Given this list of marker genes Mrps34, Hsdl2, Rtkn (NCBI Gene Id 20166), Xrcc1, Lcmt1, Rmnd5b, Slc31a1, Rab10, Ssbp1, Mgst1, Rsrc1, Mrps18a, Ppp1r3f, Mfap3l, Lonrf3, Hsf1, 9230112J17Rik, Dock7, Tubg1 (NCBI Gene Id 76340), 1700021N21Rik, Spop, Xpo4, Col4a2 (NCBI Gene Id 12827), Dsn1, Ciao1, Ppbp, Eldr, Kdelr3, Ipp, Ccndbp1, Atg9b, Sdhaf3, Or2d3, Cfap410, Strada, Osbpl3, Vav2, Ifi35 (NCBI Gene Id 70110), Nedd4, 0610043K17Rik, Idi1, Gap43, Tmem126b, Hoatz, Osbpl9, Tcf4, Srprb, Mfap5, Col1a2, Rftn1, Ghr, Hdgfl2, Qng1, Ccdc181, Nudt14, Csrp1, Tnfrsf10b, 4930486L24Rik, Uchl3, Itpr2, Fam83d, Atl3, Tctn3, Dtd2, Gapdh, Slc48a1, 4930544F09Rik, Smoc2, Mllt10, Adsl, Cdc14b, Sdcbp2, Cpa4, Slc25a16, Gjb4, Tff1, Tram1, Fig4, Eif2s3x-ps1, Serpinb9, Tbc1d1, Plac8, Camkmt, Shisa9, Phf10, Chrne, Cfap298, Ntsr1, Atxn7, Insl6 (insulin-like 6), Ccdc47, Col11a2, Tmem126a, Qrsl1, Acta2, Pde6d, Grb10, Sprr1b, Vps26c, Mlkl, Ppil2, Hpcal1, Tnfrsf23, Rogdi, Prr5l, Rbms3, Tmem176a (NCBI Gene Id 66058), Snx1, Tlr4, Calm2, Eps8l2, Tspan5, Pla2g2d, Wdr5, Snrpd1, Cdk5rap1, Tarbp2, Ltb4r2, Psma1, Gde1, Cenpk, Dkk3, Gjb5, Acsl4, Chpt1, G6pdx, 6330403L08Rik, Ofd1, Rpain, Zbtb9, Ccne1, Pxdn, Alox5, Chmp4c, Exoc3l4, P3h3, Hmg20a (NCBI Gene Id 75713), Etnk1, Pex3, Rp9, Celsr3, Ttc39c, Unc5cl, Mnat1, Ccdc88c, Farp1 (FERM, ARH/RhoGEF and pleckstrin domain protein 1), Stx8, Spdye4a (NCBI Gene Id 74673), Gcsh, Tank, Cep131, Hs3st1, Tpmt, Nkiras1, Meg3, Kctd20, Ube2t, Atf5, Ptprk, Rsph9, Plin3, Slco3a1, 2610316D01Rik, Kank3, Steap3, Elk3, Ptgr1, Mbnl2, Rest, Nptx1, Slc46a1, Pycr1, Hspa14, Wwtr1, Myh6, Mtm1, Pde4b, Odf2l, Ttc7, Tmem41b, Atic, Rtraf, Cog1, Mcm2, Jak2, 1810055G02Rik, Meikin, Anxa1, Plek2 (pleckstrin 2), Ikbke, Efemp2, Lpar6, Acp6, Chaf1b, Ptp4a2, Phf6, Plet1, Ugt2a1, Pin4, Bloc1s2, Rad51, Pttg1, 2700097O09Rik, Npc1, Acot9, Pten, Cd2bp2, Ubac2, Snap29, Ntng2, Srrd, Cdpf1, Trmt10b, Tmigd1, Rcan3, Dohh, Fabp1, A930015P04Rik, Nudt21, Trim21, Cmtm3, Loxl2, Efcab15, Tsg101 (NCBI Gene Id 22088), Fbf1, Loxl1, Psmg1, Dck, Mipep (mitochondrial intermediate peptidase), Hmces (5-hydroxymethylcytosine (hmC) binding, ES cell specific), Diaph2, Tk2 (thymidine kinase 2, mitochondrial), Atp2b1, Tex2, Ldlr, Aamdc, Myom1, Echdc1, Klf13, Col4a5, Crtap, Usp17la, Nqo2, Pstpip1, Plin4, Gnb1l, Preb, Tnip1, Polr2j, Anxa6, Pccb, Spatc1, Crem, Col11a1, Nnmt, Ggct, Rexo5, Selp, Psmd10, Ubqln1, Pdxk, Ptpn11, Cdk9, Svep1, Pcdh12, Kifap3, Klf10, Lrrc8d, Matn2, Bmper, Zbed3, Vac14, Rin1, Gatm (glycine amidinotransferase (L-arginine:glycine amidinotransferase)), Dnajc7, Arhgap17, Atp6v1h, 1700088E04Rik, Abcb1a, Sap30l, 2310033P09Rik, Col6a3, Tfcp2l1, Xrn2, Scnm1, Zfp26, Psg23, Smim8, Hnrnpdl, Prim1, Ube3a, Tpd52l1, 1700010I14Rik, Tbcd, Fer, Sugt1 (NCBI Gene Id 67955), Tgfbr2, Timm21, Mus81, Dmrtc1c1, Wtap, Accs, Htra2, Tfpi2, Ms4a10, Mrpl49, Cdc45, Fam83g, Plpp1, Csnk2a1, Kif3a (kinesin family member 3A), Mplkip, Robo3, Nfu1, Shq1, Pdia5, Tmem238, Taok3, Ruvbl1, Cast, Smurf1, Prkar1a, Hyal2, Washc3, Aox3, Pwwp3a, Ptprg, Trappc2b, Ndufs3, Swap70, Taldo1, Bcas3, Plscr1 (NCBI Gene Id 54533), Pdrg1, Mark3, ENSMUSG00000125400, Cyp27a1, Rpap3, Pcgf5, 2310030G06Rik, Tpm2 (NCBI Gene Id 22004), Eral1, Prnp, Abcg8, Angpt2, Rp2, Fabp5, Clip1, Rcn1, Czib, Plscr2, Trappc6b, Ndufaf3, Adat2, Ankrd1, Ier3ip1, Nt5dc2 (NCBI Gene Id 70021), Nab1, Col1a1, Nmi (N-myc (and STAT) interactor), Cmc1, Capn1, Dnaaf8, Mrps22, Ormdl1, Klhl13, Rpa1, Dkk2, Uchl5, Hemk1, Agmat, Gsto2, Wdr54, Nid1, Riok3, Psat1, 4930438A08Rik, Ccdc103, Hmga2, Cops4, Fkbp7, Csnk1g3, Diablo, Tex9, 1700030I03Rik, 1810009A15Rik, Ptpn21, Cxadr, Snx27, Mrps28, Ttc17, Emc2, Uba2, Nans, Gemin2, Cst6, Tsc2, Hic1 (NCBI Gene Id 15248), Cdk1, Aifm1, Mlycd, Pex7, Ppat, Tbp, Dhrs7b, Dnttip1, Myl12a (NCBI Gene Id 98073), Ndufa1, Crnde, Ltbp4 (latent transforming growth factor beta binding protein 4), Samd8, Use1, Rn7s1, Pkd1 (polycystin 1, transient receptor potential channel interacting), Rgs17, Ccdc13, Gng11, Cibar1, Rln1, Nadk2, Pole2, Ccdc90b, Rbx1, Exosc3 (NCBI Gene Id 66362), Gatad2a, Ahcyl1, Ctu1, Wars2, Zcrb1, Actb, Pls3, Mib1, Suds3, Myo5c, Prss23, Wwox, Psph, E2f1, Paip1, Cenpv, Nup93, Psmd4, Sil1, Rbpj, Tjp2, Pitx1, Sfrp1, 4930407I19Rik, 1700003F12Rik, Setd6, Glyat, Abcg1, Nsmf, Cxcl14 (C-X-C motif chemokine ligand 14), Tipin, Stat6, Nid2, Tnc, Map4, Gabrb1, Eid3, Elovl7, Fam114a2, P4ha1, Cd40, Gpatch2, Agk, Myl6, Tpr, Bcl2l15, Eno3, ENSMUSG00000125971, Stk11, Snx5, Uck2, Tusc3, Rsu1, 5730480H06Rik, Dubr, Fto, A930019D19Rik, Colec12, Msh5, Prelid3b, Dcaf7, Mtap, Tardbp, 2810004N23Rik, Specc1l, Galnt2, Thbs2, Sh3d21, Gclm, Elmo2, Fkbp1a, Prl3d1, Hras, H2ax, Bcs1l, Arhgef1, Pigq, Immp2l, Gjb3, Meaf6, St3gal6, Grem1, Ppp6r3, Clns1a, Nit1, Piwil1, Ubap2, Mettl5, Ccdc34, Myh11, Cstf2, Psmc1, 3110040N11Rik, Cd2ap, Bub3, Chchd3, Echdc2, Tln1, Pdia6, Ddx6, Smg9, Bex3, Sh2d1b1, Tiam2, Zcwpw2, Slk, Fam117b, Akip1, Lmo1, Gnpda1, Dnaaf9, Fbln5, Eps8, Pcmt1, Slc22a15 (NCBI Gene Id 99953), Pcolce, Cd55, Hmox2, Cav1, Dkkl1, Sema7a (NCBI Gene Id 78407), Prpf40a (NCBI Gene Id 75419), Cstpp1, Sgsm3, Nudt4, Pa2g4, Klhdc10, Ppp1r12a, Pdcd10, Zfp593, Dpp8, Med15, Tex30 (testis expressed 30), Acadsb, Prkca, Cisd1, Kdsr, Acta1, Hrh3, Pagr1a, Il17a, Loxl3, Polr3gl, Mcm4, Afdn, 1700031C06Rik, 4833412C05Rik, Tmem192, Rab2a, Ebna1bp2, Grin2d, Hoxb3, Nmt1, Hsd3b3, Kifc3, Mrpl15, Aph1c, Trip4, Parm1, Ndufaf6, Myo5a, Bcr, Herc6, Cd8b1, Il15, Man2c1, Yars2, Slc12a2, Pola1, Nelfe, Msh2, Commd10, Dyrk1a, Hpca, Sorcs2, Ttn, Ctnnd2 (catenin delta 2), Msrb1, Ano1, Nat9, Col5a1, Septin9, Mmp10, Mmp13, Stxbp5, Ccnh, Drap1, Cox7b2, Hikeshi, Lrrc17, Exo5, Speer4d, Ogn, Tmem123, Fbxo7, Rnf38, Eva1c, Ctf1, Prss44, Dmac2l, Nubpl, P4hb, Myh10, Irx2, Lama4, Frg1, Ykt6 (NCBI Gene Id 80527), Nab2, Arl3, Brcc3 (BRCA1/BRCA2-containing complex, subunit 3), Fbxo8, Krt13, Med26, Pfn4, Htatip2, Coasy, Lmtk2, Magohb, Tmem183a, Lox, Metap1, Eloc, Tgfbi, Or2y13, Blvra (NCBI Gene Id 70105), Bet1, Npm1, Stk4, 4930579K19Rik, Dnajc5, Gykl1, Fam89a, Ggcx, Cd302, Aifm2, Atp6v0a2, Vmn1r14, Haus4, Mtarc2, Chia1, Ufsp2, Tgfa, Nbas, Osgepl1, Oxct1, Vegfc, Hat1, Sars2, 4930461G14Rik, Shc1, Srd5a3, Hdhd2, Unk, 9130221H12Rik, Tead4, Bcas2, Aspn, Mif4gd, Usp12, Tom1, Rpf2, Cyrib, Dynlt2b, 1700071G01Rik, Arl6, Commd9, Riox1, Dnajb1, Fam241b, Pacsin2, 9130230N09Rik, Zfp326, Bcl6, Ctbp2, Atp6v1c1, Poglut3, Ammecr1l, Ajuba, Atg4b, Fn1, Ltb4r1, Pip4p2, Rbm3, Dvl1, Fdx1, Sh3bp5l, Cep85l, Surf2, Gtf2e2, Dnmbp, Casp8, Cmc2, Flicr (NCBI Gene Id 78185), Map3k7, Mtx2, Endod1, Abtb3, Acy3, Psd3, Vta1, Stimate, Pak1, Gm15343, Ufm1, Daam2, Rpp30, Pgp, Mtmr9, Rnaseh2a, Ddx19a, Gtf2f2, Washc1, Sqstm1, Hprt1, Ndufaf7, Omt2b, Col12a1 (NCBI Gene Id 12816), Lncbate3, Adgra2, Lrig3, Dgka, Kdm6a, Nsmce1, Gch1, Nudt5, Areg, Xirp2, Arl8b, Iqch, Akr1b10, Dixdc1, Ostc (oligosaccharyltransferase complex subunit (non-catalytic)), Hsd3b7, Icam5, Abcb8, Agrn, Ints13, Cited2, Psma5, Parva, Cmas, Sema3e, 5330439M10Rik, Ppil3, Acot10, Hfe, Tapbp, 1700064H15Rik, Por, Stx4a, Mtch1, Abcd1, Tada3, 1600012H06Rik, 9530036M11Rik, Tsen15, 9430021M05Rik, Calu, Bicc1, Nectin1, Trim15, Pdk4, Cygb, Coa3, Plxdc2, Trmo, Psmd12, Cnnm2, Rnf138, Wnt11, Cpxm1, Mmp19, Donson, Nbn, Mthfd2, Syp, Zfp131, Emc8, Als2, Cdk16, Cfdp1, 4930466K18Rik, Ptpn22, Hint3, Gyg1, Man1a, Col6a1, Zcchc17, Serpinb8, Aloxe3, Lias, Atxn3, Pikfyve, Ppp1r13b, Erap1 (endoplasmic reticulum aminopeptidase 1), Mrpl18, Urah, Mrpl33, Chek2, Tceal1, Gzmm, Ftl2-ps, Pnkp, Atg7, Grhpr, Mmp3, St6galnac5, 4930523C07Rik, Abhd6, Psmd14, Nectin3 (nectin cell adhesion molecule 3), Cers4, Impa2, Cpq, 6030440G07Rik, Haus8, Eif2b1, Dscc1, Ddah1, Fbxo6, Dpy30, Cthrc1, Tprkb, Gpc4, Gkap1, Map1lc3b, Gps2, Krt12, Ngf, Tpm1, Smim20, Rpl22l1, Akap8l, Gemin6, Slc16a7, Mcl1, Dnajc15, Ppcdc, Dok4, Bmal1, Rims1, Ncapd2, Smc5, 4930515G01Rik, Rbl2, Rfc4, Ahr, Rassf7, Abhd5, Krt20, Cnn1, Gipc2, Spast, Dpm1, Bola1, Setdb1, Rnf225, Ssu72, Rgs7, Fah, Mok, Gsk3b, Cmip, 4932442E05Rik, Twsg1, ENSMUSG00000135048, Atp6v0d1, Tomm34, Gpx7, Prkg2, Gins4 (GINS complex subunit 4), B4galt1, Adrb2, 5730455P16Rik, Esd (esterase D/formylglutathione hydrolase), Cenpu, Dnajc24 (DnaJ heat shock protein family (Hsp40) member C24), Slc8a1, Ddx59, Myl9, Chaf1a, Tln2, Chst14, Mre11a, Rrad, Copz2, Gask1b, Fgfrl1, 5830437K03Rik, Ocel1, Aarsd1, Papola, Ahnak, Gdf3, Mup4, Myo1h, Usp47, Tbc1d7, Atp6v1d, Cln3, Siae, Arpc5l, Sorcs1, P3h4, Ube2e3, Dph5, Cab39, Gla, Pex14, 1700048F04Rik, Exosc8 (exosome component 8), Ikbip, Dock2, Utp11, Iftap, Uqcrc2, Psma4, Dut, Cd38, Krtap14, Nova1, Klhdc8a, Asph (aspartate-beta-hydroxylase), Dusp19, Prkar2a, Zw10, Eef2kmt, Ube2r2 (ubiquitin-conjugating enzyme E2R 2), Fxr1, Vps33a, 8430429K09Rik, Fads2, Ywhab, Whrn, 1190005I06Rik, Memo1, Krit1, Tomm5, Ociad2, Ckmt1, Septin11 (NCBI Gene Id 67780), Dapk1 (death associated protein kinase 1), Scarb2, Tmem127, Chmp1b2, Clpb, Lrrfip2, Nthl1, Mfap4, Ccl21a, Adam23, Mustn1, Slc4a7, Sult4a1, Ap3s2, Atpsckmt, Ccnl2, Ctcflos, Stoml2, Fam114a1 (family with sequence similarity 114, member A1), Polm, Ascc2, Timm44, Zfp777, Pgpep1, Scamp5, Rufy1, Sgms2, Apobec3, Vps26b, Btf3l4, Psmb7, Gstz1, Itgb4, Acss2, Ccdc80, Fbxo43, Sdr39u1, Mad2l2, Mcm3, Cd55b, Ube2b, Rbms1, Gtf2a1, 4930519L02Rik, Fbxw4, Mettl6, Aatf, Drg1, Nup43 (nucleoporin 43), Col4a1, Disp1, Atp6v1g2, Sos1, Tbata, Trappc5, Sytl1, Dcbld2 (NCBI Gene Id 73379), Nfs1, Lmnb1, Sgcd, Actg1, Psmc2, Araf, Tmem86b, Arhgef7, Msra, Vasn, Retsat (retinol saturase (all trans retinol 13,14 reductase)), Slc17a9, Mxra7, Acox2, Asf1b, Mfsd2a, P3h1, Cytip, Kcnab3, Ccdc22, Amacr, Col5a2, Agpat5, Ppic, Vrk3, Arhgap27, Slit2, Sarnp (SAP domain containing ribonucleoprotein), Fmod, Mrpl17, Mocos, Sumo2, Adh5, Gzmd, Sass6, Dnaja4, Tmem65, Vamp4, Vps36, Nmu, Aimp1, Mrps9, Hook2 (hook microtubule tethering protein 2), Jade1, Tob1, 1810059H22Rik, Epha1, Gstt3, 4930453H23Rik, Cacna1c, Lrrc28, Rwdd1, Med6, Gkn1, App, Atp6v1e1 (NCBI Gene Id 76771), Ptx3, Rabep1, Tomm20, Enpp1, Itgb3bp, 2500002B13Rik, Spem1, C030006N10Rik, Tpst1, B4galt3, Krt23, P2rx6, Or10j5, Uhmk1, Ddx55, Dpep1, Socs2, Pdf, Fmo5, Pias2, Ext1, Kpna4, Neil1, 5430416N02Rik, Ezh2, Tex261, Ltbp3, Gm11837, Anp32b, Slc35b1, 1700012B09Rik, Ccdc86, Vamp5, Klk5, Fnta, Aagab, Glod4, Rala, Sptlc1, Krt16, Stx12, Slc44a1, Rab20, Ccdc178, Dbnl, Rom1, Krt1 (NCBI Gene Id 223916), Sgce, Fgd6, Car13, Coq7, Tuba1a, Ptprz1, Nmt2, Cux1, Rasa2, Plekhb2 (pleckstrin homology domain containing, family B (evectins) member 2), Pfkfb3, Eaf1, Ogfod3, Rnf31, Dnajc18, Arsb, Rab31, Bmpr2, Tubb6, Angptl4, Hacd4, Rnf121, ENSMUSG00000134326, Ube2j1, Pgm1, Crabp1, Tollip (NCBI Gene Id 80650), Zfand6, Epg5, Per1, Slit3, Mmp23, Mettl1, Gmpr2, Ptprm, Tmbim6, Rhob, Flt1, Mecr, Cbr4, Slc25a14, Git2, Fstl1, Mrps18c, Spa17, Lgals8 (lectin, galactose binding, soluble 8), Cda, Atox1, Ube2k, Akr1b8, Mrnip, Sik3, Ppm1m, St3gal4, Dynap, Stam2, Slc25a20, Ptn, Crispld2, Rmdn1, Mos, Stx18, Acot13, Mcm5, Myo7a, Ccnd2, Tcf19, Pick1, Srpx (sushi-repeat-containing protein), Sin3b, Pigp, Ptprs, Rfc3, here is a description of the gene set: Late response genes: differentially expressed only 12 h after UV-C irradiation of MEF cells (embryonic fibroblast). Phosphorylation is important in p53-mediated DNA damage responses. After UV irradiation, p53 is phosphorylated specifically at murine residue Ser389. Phosphorylation mutant p53.S389A cells and mice show reduced apoptosis and compromised tumor suppression after UV irradiation. We investigated the underlying cellular processes by time-series analysis of UV-induced gene expression responses in wild-type, p53.S389A, and p53(-/-) mouse embryonic fibroblasts. The absence of p53.S389 phosphorylation already causes small endogenous gene expression changes for 2,253, mostly p53-dependent, genes. These genes showed basal gene expression levels intermediate to the wild type and p53(-/-), possibly to readjust the p53 network. Overall, the p53.S389A mutation lifts p53-dependent gene repression to a level similar to that of p53(-/-) but has lesser effect on p53-dependently induced genes. In the wild type, the response of genes to UV irradiation was strictly biphasic. The early stress response, from 0 to 3 h, results in the activation of processes to prevent the accumulation of DNA damage in cells, whereas the late response, from 12 to 24 h, relates more to reentering the cell cycle. Although the p53.S389A UV gene response was only subtly changed, many cellular processes were significantly affected. The early response was affected the most, and many cellular processes were phase-specifically lost, gained, or altered, e.g., induction of apoptosis, cell division, and DNA repair, respectively. Altogether, p53.S389 phosphorylation seems essential for many p53 target genes and p53-dependent processes. from publication Bruins W, Bruning O, Jonker MJ, Zwart E, van der Hoeven TV, Pennings JL, Rauwerda H, de Vries A, Breit TM (PMID 18195040) species: Mus musculus Mouse Gene Set: BRUINS_UVC_RESPONSE_LATE